The following is a description of a gene set: Human Gene Set: REACTOME_UNBLOCKING_OF_NMDA_RECEPTORS_GLUTAMATE_BINDING_AND_ACTIVATION Unblocking of NMDA receptors, glutamate binding and activation studied in species Homo sapiens, and this is the list of marker genes: CAMK2A, DLG3, ACTN2, DLG2, GRIN1, GRIN2A, CAMK2D, GRIA4, NEFL, DLG1, LRRC7, CAMK2B, GRIN2B, GRIA1, DLG4, CALM1, GRIA3, GRIA2, GRIN2D, GRIN2C, CAMK2G